The following is a description of a gene set: Genes containing one or more binding sites for (BARX2) in their promoter regions (TSS -1000,+100 bp) as identified by GTRD version 20.06 ChIP-seq harmonization. from publication Yevshin I, Sharipov R, Kolmykov S, Kondrakhin Y, Kolpakov F (PMID 30445619) species: Homo sapiens Human Gene Set: BARX2_TARGET_GENES, and this is the list of marker genes: C2orf49, CENPP, PFKM, MIR3143, SYMPK, PCBP2, GOLT1B, MTFR1, HS3ST3B1, ASB16-AS1, TFDP2, TLE4, STK40, TMEM70, GOLGB1, EIF3E, HINT2, PISD, YPEL5, ALKBH7, GRPEL2-AS1, MED30 (mediator complex subunit 30), CRAMP1, COQ7, FERRY3, UFD1, CCDC28A-AS1, ZNF408 (zinc finger protein 408), RPS18, ARPP19, RSPRY1, NAPEPLD, ZSCAN5A-AS1, CS, ATF7-NPFF, ITGB8, NHP2, PQBP1, JUP, KCNIP2-AS1, SLC2A8, DROSHA, ZNF524, ESCO2, ANP32E, NCK1-DT, LTN1, TMBIM4, SLC25A36, LSM1, HEXIM2-AS1, ENSG00000261335, BTD, PSMD4, ATG9A, KDM8 (lysine demethylase 8), TRIM45, TCF19, ENTR1, DDX41, SUCO, FIZ1, WDR37, CFAP119, RGP1, MAP3K7CL, COX14, AKAP11, RPL34, WRAP53, MYL11, CCDC12, ZNF322, P4HB, PSMB7, SAMD13, RASAL2-AS1, IVD, CYP2R1, ZNF689, AIRIM, STPG1, NFX1, CALR3, NFATC2IP, FBXL15, PC, TMEM205, EFCAB11, GUSB, LRRC46, GPHN, NEK2, MRPS12 (NCBI Gene Id 6183), CEP41, MPP7-DT, HCG27, ZNF714, MROH8, TYW1B, ZNF277, TRMT44, LCMT2, RLN2, DMRT2, ANAPC7, LMCD1, ACKR2, NEDD4, CAPZA1, BDNF-AS, C2CD5, ADCK5, ZNF837, PSME3IP1, RFWD3, FASTKD3, ZNF8, COPZ1, HACL1, RPL36AL, THOC1, TARS2, MDH1, PRDM4, FAM120AOS, ZDHHC16, HUWE1, BZW2, ADAMTSL4-AS1, SP110, PLEKHG2, ALDH6A1, ARHGAP19, MPND, RBKS, KIFAP3, MAFTRR, IFTAP, PIKFYVE, ELP4, ZNF212, ERCC6L2, RBBP4, ANKHD1, FBXO45, PSMA3, NAGPA, SPTLC2, TESK2, ZNF830, CCDC61, H2BC21, SPC24, SUCLG1, ECSIT, RFX5, WDPCP (NCBI Gene Id 51057), PMEL, CACNB2, TPD52L2, CA5BP1, ZNF441, WDR46, TIPIN, H2AZ2-DT, CLDN4, HDAC1, MED21, FUZ, ZNF785, CDC20, UBAP2L, SCP2, IPO11, OGA, ISY1-RAB43, RAD9B, YIPF4, EXTL2, HAX1, GNA12, ERC1, SPC25, EIF5A, ECT2, IMMP1L, MXD1, GTPBP3, RPAIN, RNU6-92P, COP1-DT, IFT172, SEC22C, ITGA7, RPL34-DT (NCBI Gene Id 285456), CSE1L, GTF2B, AP4M1, RAB3A, ZNF281, GPRC5C, PRPF19-DT, HDGFL2, MVB12A, RAD54L, SETD5, GATAD2B, PLEKHG3, NDUFA6, GIPC1, AVL9, ISY1, DNM2, NKTR, GATB, PWWP2A, DUSP7, LETMD1, ENSG00000267698, TMEM30A, H2BC18, DGLUCY, DRC3, PRR14, ZBTB8OS, RBM14-RBM4, ZNF654, RNF8, PMPCA, TNFSF4, GPATCH3, MTHFD2, ZNF263, ZKSCAN4, DCP1B, PKP4, CDK5RAP2, NIP7, ECD, CENPF, RNFT2, TRIM26, CATIP-AS1, TARS1, ARL16, DLAT, MSH5-SAPCD1, PET100, TMEM60, SWSAP1, KIF14, MIR4450, GIPC2, THAP5, MORF4L2-AS1, HRH1, WASF2, EXOSC2, ZNF44, H2BC26, LIPE-AS1, MIR4479, METTL15, STAG3L5P-PVRIG2P-PILRB, TNFAIP8, POC1B, PSD, RBM26, ACTN1-DT, CCT5, HDAC6, LIPE, MPDU1-AS1, IP6K2, FRMD5, FAM111B, HLA-C, TRAK2, XPNPEP1, PTK2B, C2orf49-DT, CHRNB1, COPS3, SWT1, RARS2, DUSP19 (NCBI Gene Id 142679), ZNF564, TXNDC16, PDK2, U2SURP, BSCL2, CCNB1, MIR22HG, GGCX, GORASP1, PPP1R37, BCAT1, ADAP1, TSR2 (TSR2 ribosome maturation factor), NUMA1, MAGT1, CNNM2, TYK2, CENPH, MIEF2, SLC23A1, SMG8, NMT1, QRSL1 (NCBI Gene Id 80136), BECN1, RAP2A, DCLRE1C, C14orf93, HYCC1, TMEM259, ESS2, SCAND2P, RGS16, CREBRF, ALG11, EMC1-AS1, MIR638, C5orf22, OSBP, TTF2, ARMH1, CARS2, FHIT, DBP, RBM27, NNT-AS1, PLA2G4E-AS1, CHCHD6, ANKRD27, DGKA, EIF3K, HEMK1, PCAT7, RPUSD3, TATDN3, PNPO, GSTA4, RPL18A, HSCB (HscB mitochondrial iron-sulfur cluster cochaperone), UBR4, GLO1, SNX12, ZNF426-DT, NOL8, IFT27, ZNF131, KIF2A, NSL1, OSCP1, SIVA1, TMEM126A, CETN2, ZNF449, NCAPD3, C2orf92, TRAFD1, MSL3, LINC02474, ERBB2, ACAA1, ZFYVE16, ZBTB11, MYH9, TMOD3, ARL6IP1, WDR75, PSMC2, ISG20L2, PXN-AS1, PPWD1, HAGH, TTC16, RITA1, NEMP1, H2AC7, ARHGAP19-SLIT1, MYO1E, H2AJ, HNRNPH2, FAM83D, ZNF138, TRIP10, SP2-AS1, RBM48, DERL3, GTF2IP13, GOSR2-DT, CCDC66, ZNF846, UBB, DDX39A, AARS1, ZNF688, FAM185BP, ZNF77, ARRDC4, MEX3C, ILF2, DYNLT2 (NCBI Gene Id 6991), LINC00938, CPSF4, TAF13, MBTD1, HMGB1, CDKN1B, SET, ARMCX5, HNRNPR, POLR1B, IK, LSM5, MIR548AW, EIF5, TUBB4B, PPP2R5E, NEK2-DT, PAF1, PGAP2, CENPQ, PNO1, HINFP, HAUS2, PTRH1, SLC4A1AP, TP53BP1, NPHP4, ANKRD54, SQSTM1, DESI1, ACAT2, F11R, SNORD45B, RAB2B, RN7SKP192, FKBP14 (FKBP prolyl isomerase 14), POLR2I (RNA polymerase II subunit I), PITX2, RAD51AP1, MRPS30, ZBTB11-AS1, ADAMTSL5, GARNL3 (GTPase activating Rap/RanGAP domain like 3), SH3RF2, GTF3C5, ELK1, MSH5, LIN52, PACSIN2, JPT1 (NCBI Gene Id 51155), RTRAF, RPS10-NUDT3, IKZF4, BTBD10, GALNT9, RHCE, CAPN10, IFI6 (interferon alpha inducible protein 6), MATCAP1, NUDT16, NUDT2, LGR5, ZSWIM8, UBAP1, PCBP1 (NCBI Gene Id 5093), STX18-AS1, SESN3 (sestrin 3), SFPQ, UBE2T, NDUFA2, KBTBD8, NF2, HAPSTR1 (NCBI Gene Id 29035), THAP1, PIP4P1, ZNRD2-DT, ABT1, ACTR1B, FUT8, GANC, PTBP1, BBX, ZSCAN2, STT3B, TCEA1, UBE2I, SNRPA, ACTG1P25, P4HA2-AS1, ZKSCAN5, TMEM39A, SCAMP2, TCOF1, MAPDA, THOC1-DT, DDX49, LRRC40, SLC52A3, AKR1D1, DNAJB5, AMBRA1, C14orf28, ENPP4, CENPK, PTPRK, CALM3, YIPF3, ASPM, MED29, FLAD1, FUBP1, LINC01572, COX16, ZNF799, WARS2-AS1, RBM10, ZFYVE21, DNAJB5-DT, NUBPL-DT, SMARCC1, SIRT2, CAND1, PPP2R3C, EXOC4, TFPT, EDC3, RNF6, XPO6, PFDN6, FBXO38-DT, MRTFA, ZNF774, SETDB2, HOXB-AS3, FDFT1, SKIC3, CCDC146, C9orf85, RNF13, IGFLR1, ATP5MG, FOXRED1, IMPDH2, DUSP16, PSAT1, RPL24, HLA-A, CYB5B, FAM174B, H2AC6, C10orf143, ARSK, L3MBTL2, UBE4A, MIR301B, EXOC2, TPRA1, RBM26-AS1, GET3, RPA2, RPS4X, LINC01635, RAB11A, KMT2E, FADS2, BROX, RAB8A, YWHAQ, MACO1, TMEM184C-DT, GLTC1, NSDHL, COX8A, REXO5, FBXO16, WARS2 (NCBI Gene Id 10352), OTUD5, DOCK7, RAD51B (NCBI Gene Id 5890), BTF3L4, CAPS2, TFCP2, KCTD21-AS1, DCTN6-DT, PEX16, PPP1R21, ECI1, PPP1R3F, OARD1, C4orf33, SHPK, ARID4A, RNF167, DMAP1, COQ10B, NUDT21, TRIM68, PRR13, HCP5, TRIP11, METTL13, STX18, CDC20-DT, TARS1-DT, ISOC2, ZRANB3, TCTN3, UTP18, H2BC12, UBP1, CDCA3, HLA-F-AS1, TMUB2 (transmembrane and ubiquitin like domain containing 2), SPATS2L, MMAB, IQCD, NUBP2, ESR2, REXO4, NEU1, CCDC148, TSACC, H2AC12, HEXA, SARS2, CKAP2, CFAP418 (cilia and flagella associated protein 418), PLCXD2, WDR77, RPL5, ZFAND6, UBE3B, IDH1, ZNF302, FAM53C, HNRNPUL1, MRPL22, ENSA, AKAP8L, RAB4B, ZNF731P, CCT2, SFXN3, ZNHIT6, COG8, CNPY2-AS1, CAMTA1, TDP1, MUL1, HMGXB4 (NCBI Gene Id 96789), SPAG5-AS1, FAM76A, ILVBL, APTR, ZNF57, HNRNPK, CHAF1A, ZNF426, MSTO1, CTNS, SF1, AHRR, TIMM50, H2AC25, NUP43, TTI2, ZNF680, RN7SK, SNORA78, LAS1L, STAT3, LARP7, H2BC3, KBTBD2, HGS, UBE2F-SCLY, DIAPH1-AS1, LINC01232, DARS2, RRM2, FMN1 (formin 1), MDM1, ZNF669, ZNF8-ERVK3-1, C12orf75, MRPL9, CRTC3-AS1, CD101-AS1, FNBP1P1, SCAF11, SLC30A9, BRIP1, CDR2, ZNF726, TSPAN31, RPL13A (ribosomal protein L13a), PREPL (prolyl endopeptidase like), LAMTOR4, GART, OGFOD1, ST7L, RNF34, MBD4, GCDH, LZTFL1, NCOA2, SHKBP1, TMA16, CREB3L2, ITFG2-AS1, DIAPH1, FKBP3, DHODH, ADPGK, GPAA1, LINC01970, DCP2, TFIP11, PAK4, SAE1, NBR1, MSX2, HSPA2, MICE, XRCC3, XAB2, DCAKD, RFXANK, COPS7B, GLRX5, PTCD1, MPV17L2, KRTAP4-17P, AP2A1, METTL25, SCLT1, SNRNP40, KAT6B, TSSK6, RGS20 (regulator of G protein signaling 20, NCBI Gene Id 8601), SNRPF-DT, DDX46, ENSG00000275765, SLC39A9, DCAF15, TUBB, PBX3-DT, SRSF6, CPEB4, SLC19A2, NDUFS3, IARS1, LRRC51, ANKRD49, PITPNM1, TCF3, EIF2B3, TDRKH, TMEM97, PSME2P3, FAM13A, HLA-E, RING1, CBX5, MRPS15, FYN, LMCD1-AS1, UNG, CEP44, SLC35B1, ANAPC15, PSMA5, CYB5A, ATP5MC1, ZNF442, MIR5188, WDR89, ENSG00000268129, TXNDC12, STX3, RPS19BP1, MED24, MKNK1, AREL1, EPOR, PGD, S100PBP, HSPA5, ANKRD11, SRP9, MAP4K1, ETFA, PDZD7, YARS1, ZNF691-DT, KMT5A, SEC61G, ZNF678, DNAAF3, LINC01843, CCDC159, TOP2B (NCBI Gene Id 7155), KALRN, STAG3L5P, THUMPD3-AS1, TMEM134, POC5, MRPS23 (mitochondrial ribosomal protein S23), PRADC1, CCT7, RNA5SP180, SRRM5, NDUFS8, MAPK14 (mitogen-activated protein kinase 14), TYSND1, PRMT1, SF3B5, TOMM40, ACAA2, PDXP, NFYA, CCDC115, NFYC, ALG5, GALNT9-AS1, H2AZ2, SMTN, ZNF555, RAB7A, ATPSCKMT, DLGAP4, DCTN4, FRYL, PCDHGC3, RAB11B, HLA-F, CDK1, ZMAT2, BABAM1, RBBP5, SNAI3-AS1, HEXIM2, SPA17, BRPF3-AS1, CKAP2-DT, EDEM3, BORCS8-MEF2B, DOCK4, KIF9, PPP1R12B, TOP2A, C1QTNF6, MTMR4, TTC32 (tetratricopeptide repeat domain 32), ZRANB2-DT (NCBI Gene Id 100852410), NUMB, MSANTD4, MPP2, TOMM22, RNU2-17P, CCNB2, LINC01719, CTNNA1, NNT, UQCC1, RHOF, MRPS11, EVI5L, DCAF7, ENSG00000255647, SLU7, SIN3A, PDAP1, SPRY4, RBM3, MCCC1, ENKUR, ZBTB22, TRAIP, KLHL18, AURKB, RNU5E-1, CDC25A, MEF2C, HNRNPC, VPS4B, CIC (capicua transcriptional repressor), NABP2, ZNF526, FAM177A1, TCP11L1, WAS, H2AC11, MORN4, ABHD2, TMEM67, SCAI, TOM1L2, SPSB3, NAIF1, LMBR1L, DLGAP5 (NCBI Gene Id 9787), ELAC2, KPNB1-DT, PPP1R21-DT, ALDH4A1 (aldehyde dehydrogenase 4 family member A1), LPXN, UTP11, ENSG00000207751, FGD5-AS1, OIP5-AS1, RRAGAP1-AS1, POLR3A, IQCC, VASH2, APRT, CENPM, STAP2, TTC32-DT, H2BC11, TAF3, CEP164, PSMB3, RPL39P40, FAM149B1, CEP20, OXNAD1, VPS52, NFE2L1, SLC25A42, RPL23A, FOXM1, YIPF5, CCDC47, WBP1, FAAP24, UBFD1, SEC1P, TPI1P2, DHRS7B (NCBI Gene Id 82068), ARMC1, AASS, DELE1, FAM228B, CD2BP2, PTMA, STRADB, BAG4, LIM2-AS1, ZWINT, CAT, CMC2, DNAI3, TBCB, ZRANB2, HIGD1AP5, PDP2, RBL2, RPLP0, ZNF8-DT, KICS2, MAIP1 (NCBI Gene Id 79568), MRPS31P4, PEF1, VTA1, MTRR, UBQLN1-AS1, GPR137C, GPR108, EIF2B2, DNAJC28, MTHFD1, DNAAF8, ZCCHC17, RMI1, FAM111A-DT, MDFI, RNA5SP18, MPHOSPH9, MICA (MHC class I polypeptide-related sequence A), FBXO5, PRPF8, H2BC15, ZNF431, SNHG9, CAB39L, PEX13, TMEM94, DCTN5, KDM4A, CENPA, CDR2-DT, ARHGAP1, PPP3CA, CENPI, HNRNPA1, ENSG00000187951, C1orf226, LENG1, TPR, ZSCAN20, SNRPB2, ARID2, INTS3, PHPT1, RNF5, GOLPH3L, PSMD3, FKBPL, PNPLA8, STARD4 (StAR related lipid transfer domain containing 4), H2BC4, ZMAT5, SLC25A25, SPAG5, BANF1, ARHGEF9, ADGRF3, CCDC18-AS1, RFX1, ZNF627, PRDM10, STXBP5-AS1, NUP88, SFXN5, CFAP43, EFCAB6, RPS25, LINC01140, ZNF267, MRPL33, XPO1, SNHG10 (small nucleolar RNA host gene 10), G3BP1, TMPOP2, TMEM38A, YJU2, MSMO1 (methylsterol monooxygenase 1), CEP89, HHIP, RNU6-2, SNRPD1, FTO, MIR3913-1, H3-3B, ZNF143, HBP1, SNUPN, CREB3L4, AKTIP, WBP2, TXNL4B, PDE4D, GPR19, SLC12A9, APOL2, RPS15A, CPOX, ZNF75D, RPS2, GRK6, TMEM184C (transmembrane protein 184C), PIK3IP1, POGLUT2, CCDC77, AIDA, RTN4IP1, NRXN3, ERAL1, UCP2, COX18, CAMTA1-DT, RAB39A, ZSWIM3, PCLAF (PCNA clamp associated factor), NAA60, HMGCR, ZNF195, AP3M2, TWNK, ZMYND8, WDR81, MORF4L2, SUDS3, GDAP2, TMEM258 (NCBI Gene Id 746), PRPF19, SARNP, PROSER3, FAM117A, EFCAB6-DT, LSM14A, LRRC28, TCF12, GCA, C7orf50, DCTN2, MIR3181 (microRNA 3181), MTOR, PSMA1, EHD4, SPRED2 (NCBI Gene Id 200734), CDK19, GSPT1, ALG1, KLHDC10, CGGBP1, TMEM167B-DT, TYW5, PPP5D1P, PMF1-BGLAP, ZNF687, SELENOI (selenoprotein I), POLR3GL, ZNF563, ADPGK-AS1, HADH, KANK3, PI3, BUD31, ZNF397, AEN, TFIP11-DT, SNORD13 (small nucleolar RNA, C/D box 13), TMEM218, TMBIM6, KBTBD4, ARHGAP11B-DT, H2BC14, SP3, SEMA4F, LTB4R2, ERH, ABHD17B, PPP4R3A, AFMID, MRPL16, CCHCR1, KIF1B, PDXP-DT, USP30, NCK1, WDR53, MCCC2, FAM229B, MMUT, CYP4F12 (cytochrome P450 family 4 subfamily F member 12), PRMT5-DT, NECAP1, MAP3K9-DT, ACTL6A, MVK, SGO2, CKAP5, CCDC192, MRPS22, ZFP91, ENSG00000224478, TCP1, SPAG7, MRPL18, FRG1, CCT3, SLC26A2, DDX50, ERCC6, TRMT1L (NCBI Gene Id 81627), SERTAD1, NRL, WDR59, BMAL1, KMT5C, SEC23B, FDPS, PALB2, RLF, RMND5A, SYVN1 (synoviolin 1), KIFC1, UTP20, HFM1, PLK4, ALG2, ZNF695, WBP11, ZNF574, MIS18BP1, UBE2S (ubiquitin conjugating enzyme E2 S), ATF7, WDR36 (WD repeat domain 36), PGP, LRRC57, MTFR2, WDR83 (NCBI Gene Id 84292), FEN1, RAB8B, CHCHD3, NID2, RAB3D, ALG8, PPP2R1A, MAP3K9, LRP4-AS1, INF2, PTPN4, GSK3B-DT, TMEM161A (transmembrane protein 161A), TRAPPC4 (trafficking protein particle complex subunit 4), H2AC20, QRICH1, VPS26C, NKIRAS2, SFSWAP, SHC1, SPAST, AKR1E2, MRPL46, ARMH4, KHSRP, ZNF519, SMC3, MIR4482, CTNND1, ARL13B, G3BP2, ERCC6L2-AS1, SENP1, IDI1, STARD3NL, BLM, LINC00513, DMAC2, BEST3 (NCBI Gene Id 84821), BPNT2, MTF1, DDX42, CALU, NOL6, LCA5, LAPTM4A-DT, ABCA7, TOX4, NME1, TNPO3, H2BC13, ERAP1, ATP5PB, TNPO2 (NCBI Gene Id 80048), RNF26, COQ8A, PRMT5, SLC12A6, CDK16, H1-12P, TMEM256-PLSCR3, BLOC1S1, USF3, SON, EIF1AD, SUPT7L, CTSD, SLC39A3, BICD1-AS1, SESN2, DPH1, CCT8, SAMM50, PPFIBP1, FBXO38 (F-box protein 38), RPL22L1, PSMA3-AS1, USP5, SP2, CHCHD2, GFI1B, ERCC2, H2AC13, H3C1, RAD52, METTL3, HYKK, STIL, ZNF576, RAB29, KCTD10, PER1, CSTF3-DT, TRAPPC6A, ORC2, TAOK3, TPGS1, YIF1A, TUBA5P, GEMIN6, DMXL1-DT, PLEKHH1, ZFP90, HOXA-AS2, UPP1 (NCBI Gene Id 7378), MTMR12, NR2C2, LIN7C, RBM42 (NCBI Gene Id 79171), NFKBIB, TMED10, MRE11, BTN2A2, MRPL48, TBC1D10B, AADACP1, MLEC, CD2BP2-DT, GATAD2A, FAN1, TTC33, SLC25A28-DT, ULK4, SLC11A2, FAM72A, HMGN5, CSE1L-DT, TSC1, GOT1-DT, HEXA-AS1, CANX, ELMO2, ZBTB5, PFDN1, TBCK, RPS10, ANAPC5, ZNF823, ZNHIT3 (NCBI Gene Id 9326), CNOT1, PAN2, NDUFB11, PBXIP1, NEK10, ATF7IP2, H2AX, DNAJB4, MAP3K12, BRD2, DOLPP1, TK1, RPL41, UBC, ATP7B, MYH9-DT, ING1, GAR1-DT, TRAM1L1, SMU1, PANK1, PLA2G6, CDC23, PHF14, DBT, STAT2, HTD2 (hydroxyacyl-thioester dehydratase type 2), MLH1, PNP (purine nucleoside phosphorylase), ZNF691, ZFHX3-AS1, BPGM, OXSR1, DPH3, MCM7, LINC00944, UBE2C, CCNG2, KCNAB2 (potassium voltage-gated channel subfamily A regulatory beta subunit 2), PRC1, CYLD, SEC61B, FAM204A, ZNF687-AS1, ACOX3, NOP2, MIR4999 (NCBI Gene Id 100847049), NOLC1, ANKS3, LINC01089, MICAL3, KIAA1191, GSTO2, TTLL5, TLE3, CARF, INO80, CDC25C, RSBN1L, AK2, PANK2, SELENOF, LPP, FBXL20, BUB1, SYPL1, C2CD3, TTC23, TMEM143, CRHR1, UGP2, HOXB3, HSD17B12, GGCT, IFRD1, PAK1, BTN2A3P, RBSN, ZNF92, CYB5RL, PRDM10-DT, GUSBP18, EBP, C19orf12, PICK1, ETFBKMT, DYNC2I2, TMEM87A, DNAH6, NR1H2, GYS1, LINC-PINT, CCNG1, VAMP8, SYNGAP1-AS1, TRAF2, PSMB10, RAD54B, RECQL, CEP350, KAT7 (lysine acetyltransferase 7), ZNF48, TPCN1, TRAF7, XRCC6, ANKHD1-EIF4EBP3, ORC3, NFE2L1-DT, ZGRF1, INPP5B, ENSG00000275740, H2AC5P, CDC45, VPS29, GSK3B (NCBI Gene Id 2932), SRPRA, METTL14-DT, AGPAT1, RSPH4A, FXR2, H2AC15, FANCG, ACTMAP, CENPX, TMEM167B, ARAF, MRPL37, ACOT8, TIMM17A, MCM5, SMIM7, PLPBP, IMP3, CACTIN, PRPF31, DACT3, RWDD1, TEF, CHD6 (NCBI Gene Id 84181), KANTR, RNF40, ETV5, PSMA2, SSR3, WDR3 (WD repeat domain 3), TIMM17B, BCKDHB, BAIAP3, PCYOX1L, RAB5B, HSPA2-AS1, AIMP1, SNORD42B, ELOVL5, FAM161A, BAG6, ORC6, HSPA5-DT, METTL14, SLC25A19, SUPT4H1, PPP2R5D, KCTD16, CKS2, H2BC7, HS2ST1, UQCRFS1, ZNF273, PPME1, ZHX2, DDOST, COX6B1, EHBP1, FDXR, PHB1, NRDC, PYM1, INTS4 (integrator complex subunit 4), MKS1, ORMDL2 (ORMDL sphingolipid biosynthesis regulator 2), SNAPC3, WBP1L, TMEM53, VPS35, CNEP1R1, WDR6, MIIP, BCAS3, TMPO, H3C11, NUP98, POLR3F, ARHGAP26, TNRC6B, CYTH2, COP1, RPGRIP1L, EIF2AK3, MST1, PDE6D, METTL2B, GLA, FICD, KPNB1, CIDEB, STX5-DT, CNOT3, QTRT2, ZNF101, HSF2, ZNF443, WDR13, WDCP, CSNK1G3, COQ7-DT, BTN3A2, GCSH, ZNF597, INCENP, PDCL, IL23A, MZT1, WDR45, LPCAT4, RNF123, ZNF343, ANKHD1-DT, KLF5, ELOC, MTRFR, TYW1, DCLRE1B, TTC21A, CREB3L3 (NCBI Gene Id 84699), GAR1, POLR2H, ATG3, ZSWIM1, SLC25A11, PCF11, TMEM160, CDC42EP4, MRPL43, MOSPD3, NDUFAF8, SLC25A35, ANKMY2, MRPL32, POP5, NLGN2, RIF1, MTUS1, CETN3, LINC02960, MIB2, ODR4, POC1B-GALNT4, OGDH, NFKBIZ, DDX27, STIP1, RCCD1, FOSB, PEX1, KANSL3, TOMM22-DT, ABCB8, RASAL2, AMN1, LRP6, CKS1B, LNCRNA-IUR, EIF4A1, CDC14B, SPRYD3, RPS6KA5, DNAAF10, CENPN, IQCN, PEX14, ERI3, SLC39A1, GOSR2, TTBK2, PUS10, TRIM35, BIVM, MON1B, CTR9, RELL1, ALDOA, SLC28A2-AS1, PPP6R3, PRORP, CDCA8, FAM81A, EXOSC7, SDF2L1 (NCBI Gene Id 23753), TEPSIN, LIMA1, HCG25, BTN2A1, RRP9, STAT6, DDX18, RPLP1, LINC02313, TLE6, ZFP91-CNTF, FHDC1, GHDC, ERMARD, RPS9, PEF1-AS1 (NCBI Gene Id 107985471), SEL1L (NCBI Gene Id 6400), PLK3, C15orf39, ZNF718, ANP32A, PHTF2, DDX19B, SF1-DT, TXNIP, MNS1, SDAD1 (NCBI Gene Id 55153), RUVBL1, C1orf174, MTR, PLA2G15 (phospholipase A2 group XV), USP36, NUBPL, RGS9BP, BRCA1, MED28-DT, NCLN, WIPF2, DYNLL1, TCERG1, NGDN, KPNA2, MRPL4, DNAJB9, AGL, EIF2AK3-DT, ENSG00000239137, LIN37, SRF, DAPK3, DEDD2, ENO1, VAMP1, NDUFA6-DT, UBE2F, C19orf44, SLC25A28, LYRM7, TDRKH-AS1, PIF1, MYO15B, ZNF672, PLEKHA8, CCDC51, ZNF143-AS1, E2F8, EIF3F, MAT2B, RNF181, CCT6B, PPP2R5A, CCDC191, VTRNA1-2, ANKRD34A, LMAN2, ITFG2, DIAPH3, VAMP4, IMP4, LINC00963, HIGD1A, USP1, CHCHD2P6, CYCS (cytochrome c, somatic), QTRT1, IFT122, DACT3-AS1, TMEM256, BORCS8, RPP14, SRSF11, MVD, PUM3, GLRX, RAP2B, BUB3 (NCBI Gene Id 9184), DHX38, CEP192-DT, FAM222B, SRGAP2, MCM6, PIN4, ZSCAN5A, WWOX, ALKBH6, SF3B6, COPE, ZDHHC9, CHEK2 (NCBI Gene Id 11200), CEP68, SCYL3, GINS1, MIRLET7IHG, LRRC45, APOA2, MED28, H2AC14, KANSL2, OS9, MRPS30-DT, WHAMM, TICRR, LACTB, QARS1, KDM4B, WDR83OS, CENPL, SPG7, ZC2HC1C, MYH10, PMF1, MYO9A, ACYP1, SORT1, MTAP, CEP192, FCF1, NUDT16-DT, EMC9, ZBTB9, AARS2, RBM15, SNRPF, DAZAP2, DPH2, DCTN6, FRG1-DT, SPATA24, AASDHPPT, TROAP, ZNRD2, ZNF141, EPM2AIP1, FH, TIMM10, MGAT2, WDR44, ANKZF1, TARBP2, R3HDM1, TBC1D5, SATB1, HSPB6, BLOC1S3, C2orf42, PABPN1, IRGQ, LINC01257, ATM, BORA, MLST8, ZSWIM4, PANK3, CLK3 (NCBI Gene Id 1198), CCDC30, SPRING1, PAIP2B, ZNF133, MRM1, AOPEP, ACTN1, H3P33, C12orf60, GOT1, PANK2-AS1, SAAL1, ERI2, SLBP, NONO, RAB11B-AS1, CCDC28A, MDC1, SNRPA1, SHB, HMGB2, KIFBP, FADS2B, MFN1, PAFAH2, DMXL1, HMGCS1 (3-hydroxy-3-methylglutaryl-CoA synthase 1), EXOSC8, NPAT, NDUFA13, RPS29P16, FNTB, TMA7, TNRC18, RPN2, ZNF584, DYM, SYNGR4, SEPTIN7P2, MANF, AP4B1, KIF23, HSPA9, PJA2, CLIC1, BRPF3, KIF2C, GBA1, GBF1, HNRNPAB (heterogeneous nuclear ribonucleoprotein A/B), PSME3, VPS26B, PCBP1-AS1, NIPAL3, NRAV, RPL22, RBM15-AS1, DZANK1, UVRAG, TOMM7, ACBD4, NACA, LIN54, NDUFA5, GLCCI1, UTP6, TIMM44, TPX2, CCDC59 (NCBI Gene Id 29080), OAZ3, ZNF213-AS1, PARP3, DTX4, CSTF3, IL17RD, NUP155 (NCBI Gene Id 9631), DIMT1, RPS26, VCP (NCBI Gene Id 94731), POU2AF1, RUVBL2, RPL7L1, KBTBD3, EXOSC1, NAP1L4, SFT2D1, RBM14, RALB, HEXIM1, SC5D, H3C10